The following is a description of a gene set: Mouse Gene Set: GOBP_N_ACETYLNEURAMINATE_METABOLIC_PROCESS The chemical reactions and pathways involving N-acetylneuraminate, the anion of 5-(acetylamino)-3,5-dideoxy-D-glycero-D-galacto-non-3-ulosonic acid. studied in species Mus musculus, and this is the list of marker genes: Gnpda1 (glucosamine-6-phosphate deaminase 1), Slc35a1, Gne, Npl, Cmah, Nanp, Cmas, St3gal1, St6gal2, Gnpda2, Nagk, St6gal1 (NCBI Gene Id 224053), Nans, Amdhd2, Renbp